Given this list of marker genes Zfp445, Dnmt3l, Mphosph8, Ehmt2, Hells, Dubr, Prmt5, Kcnq1ot1, Mecp2, Zfp57, Dnmt3a, Dnmt1, Rsl1, Uhrf1, Usp7, Myc, Uhrf2, Wt1, Brca1, Ctcf, Bmyc, here is a description of the gene set: studied in species Mus musculus An epigenetic gene regulation mechanism that negatively regulates gene expression by methylation of cytosine residues in chromosomal CpG islands. CpG islands are genomic regions that contain a high frequency of the CG dinucleotide associated with the transcription start site of genes. Mouse Gene Set: GOBP_NEGATIVE_REGULATION_OF_GENE_EXPRESSION_VIA_CHROMOSOMAL_CPG_ISLAND_METHYLATION